Given this list of marker genes KDM6B, H2AC20 (H2A clustered histone 20), CDKN2A, H2BC21, H2BC12L, MAP2K4, MAPKAPK3, EZH2, RING1, H3C1, H2BC1, UBB, CBX6, H2AB1, H3C15, EED, H4C1, CBX2, TXN, CBX4, H2BC9, MDM2, H3-3A, MAPK9, SCMH1 (Scm polycomb group protein homolog 1), PHC2, H2AC6, MIR24-1, MIR24-2, MAPK3, TNRC6C, MDM4, RBBP4, MAPKAPK5, H2BC3, CDK4, SUZ12, H2AX, CBX8, H2BC14, CDKN2B, H2BC15, PHC3, PHC1, H2AC14, H2BC26, TFDP2, TNRC6B, MAPK1, TNIK (TRAF2 and NCK interacting kinase), MOV10, AGO1, E2F3 (E2F transcription factor 3), RBBP7, AGO3, MAP2K6, MAP3K5, CDK6 (NCBI Gene Id 1021), JUN, CDKN2C (NCBI Gene Id 654235), E2F2, MAPKAPK2, CDKN2D, MAPK11, TFDP1, H2BC17, MAPK14, RPS27A, H2BC5 (H2B clustered histone 5), MAP2K7, H2AC7, H2BC12, MINK1 (NCBI Gene Id 50488), UBA52, H2AC4, UBC, H2AC18, H2BC13, IFNB1, H2AJ, MAPK8, MAP2K3, H2AZ2, FOS (NCBI Gene Id 2353), BMI1, TNRC6A (trinucleotide repeat containing adaptor 6A), MAP4K4, RNF2, E2F1, MAPK10, H2BC4, AGO4, TP53, H2BC11, here is a description of the gene set: studied in species Homo sapiens Oxidative stress, caused by increased concentration of reactive oxygen species (ROS) in the cell, can happen as a consequence of mitochondrial dysfunction induced by the oncogenic RAS or independent of oncogenic signaling. Prolonged exposure to interferon-beta (IFNB, IFN-beta) also results in ROS increase. ROS oxidize thioredoxin (TXN), which causes TXN to dissociate from the N-terminus of MAP3K5 (ASK1), enabling MAP3K5 to become catalytically active. ROS also stimulate expression of Ste20 family kinases MINK1 (MINK) and TNIK through an unknown mechanism, and MINK1 and TNIK positively regulate MAP3K5 activation.<p> <br>MAP3K5 phosphorylates and activates MAP2K3 (MKK3) and MAP2K6 (MKK6), which act as p38 MAPK kinases, as well as MAP2K4 (SEK1), which, together with MAP2K7 (MKK7), acts as a JNK kinase.<p> <br>MKK3 and MKK6 phosphorylate and activate p38 MAPK alpha (MAPK14) and beta (MAPK11), enabling p38 MAPKs to phosphorylate and activate MAPKAPK2 (MK2) and MAPKAPK3 (MK3), as well as MAPKAPK5 (PRAK) (New et al. 1998 and 2003, Sun et al. 2007).<p> <br>Phosphorylation of JNKs (MAPK8, MAPK9 and MAPK10) by MAP3K5-activated MAP2K4 allows JNKs to migrate to the nucleus where they phosphorylate JUN. Phosphorylated JUN binds FOS phosphorylated by ERK1 or ERK2, downstream of activated RAS, forming the activated protein 1 (AP-1) complex (FOS:JUN heterodimer). <p> <br>Activation of p38 MAPKs and JNKs downstream of MAP3K5 (ASK1) ultimately converges on transcriptional regulation of CDKN2A locus. In dividing cells, nucleosomes bound to the CDKN2A locus are trimethylated on lysine residue 28 of histone H3 (HIST1H3A) by the Polycomb repressor complex 2 (PRC2), creating the H3K27Me3 (Me3K-28-HIST1H3A) mark. The expression of Polycomb constituents of PRC2 - EZH2, EED and SUZ12 - and thereby formation of the PRC2, is positively regulated in growing cells by E2F1, E2F2 and E2F3. H3K27Me3 mark serves as a docking site for the Polycomb repressor complex 1 (PRC1) that contains BMI1 (PCGF4) and is therefore named PRC1.4, leading to the repression of transcription of p16INK4A and p14ARF from the CDKN2A locus, where PCR1.4 mediated repression of p14ARF transcription in humans may be context dependent. MAPKAPK2 and MAPKAPK3, activated downstream of the MAP3K5-p38 MAPK cascade, phosphorylate BMI1 of the PRC1.4 complex, leading to dissociation of PRC1.4 complex from the CDKN2A locus and upregulation of p14ARF transcription. AP-1 transcription factor, formed as a result of MAP3K5-JNK signaling, as well as RAS signaling, binds the promoter of KDM6B (JMJD3) gene and stimulates KDM6B expression. KDM6B is a histone demethylase that removes H3K27Me3 mark i.e. demethylates lysine K28 of HIST1H3A, thereby preventing PRC1.4 binding to the CDKN2A locus and allowing transcription of p16INK4A.<p> <br>p16INK4A inhibits phosphorylation-mediated inactivation of RB family members by CDK4 and CDK6, leading to cell cycle arrest. p14ARF inhibits MDM2-mediated degradation of TP53 (p53), which also contributes to cell cycle arrest in cells undergoing oxidative stress. In addition, phosphorylation of TP53 by MAPKAPK5 (PRAK) activated downstream of MAP3K5-p38 MAPK signaling, activates TP53 and contributes to cellular senescence. part of: Cellular Senescence Reactome Pathway: Oxidative Stress Induced Senescence